Given this list of marker genes PIK3CD, AKT2, MTOR, EGFR, PIK3CB (phosphatidylinositol-4,5-bisphosphate 3-kinase catalytic subunit beta), AKT1, AKT3, PIK3CA, here is a description of the gene set: Human Gene Set: KEGG_MEDICUS_VARIANT_AMPLIFIED_EGFR_TO_PI3K_SIGNALING_PATHWAY studied in species Homo sapiens Pathway Definition from KEGG: EGFR* -> PI3K -> PIP3 -> AKT -> MTOR Amplified EGFR to PI3K signaling pathway. Pathway ID: N00035. Pathway type: Variant. Pathway class: nt06273 Glioma.